The following is a description of a gene set: Binds to and modulates the activity of a ubiquitin-protein transferase, an enzyme that catalyzes the covalent attachment of ubiquitin to lysine in a substrate protein. Human Gene Set: GOMF_UBIQUITIN_PROTEIN_TRANSFERASE_REGULATOR_ACTIVITY species: Homo sapiens, and this is the list of marker genes: UBE2L3, UBE2N, RING1, PARK7, TRIB2, ENTREP1, TRIB1, CDKN1B, OTUB1 (OTU deubiquitinase, ubiquitin aldehyde binding 1), SPRY2, BMI1, RPL37, CDC20B, RPL5, PTEN, TRIB3, BTRC, GCN1, ARHGAP5-AS1, PEX12, RPL23, RPS15, BAG5, ZNF598, RBCK1, HTRA2, LIMK1, PIN1, FZR1, CDKN2A, RPS7, GLMN, RPL11, FBXO5, CBX8, CDC20, RPS20, FBXW7